Given this list of marker genes PPP1CA, CDK5, CSNK1E, CRY1, CSNK2B (casein kinase 2 beta), PER3, PER2, CSNK2A1, CSNK1D, PER1, CRY2, PPP1CB, PPP1CC, CSNK2A2, here is a description of the gene set: species: Homo sapiens Phosphorylation and nuclear translocation of the CRY:PER:kinase complex Human Gene Set: REACTOME_PHOSPHORYLATION_AND_NUCLEAR_TRANSLOCATION_OF_THE_CRY_PER_KINASE_COMPLEX